Given this list of marker genes ZNF385C, CCM2L, G6PC1, ATP1A2, EPPIN, SLC4A1, PPY, TNFRSF9, PLCB2, CIBAR2, NHLH1 (nescient helix-loop-helix 1), HDC, CDH7, CNTNAP2, MYL2, PKLR, OR6B2, SP6, CCDC187, SLC13A2, ABCG5, LCN8, IL17RE, FUT7, KISS1, RD3, TRPM2, NR0B2, KCNIP3, SLC17A7, ADAMTS13, PLCD4, CDHR2, LRCOL1, SEPTIN12, PDZK1IP1, PAX4, SP7, MRGPRG, BTBD17, SLC45A3, MMEL1, CLSTN3, STRA6, ENTPD8, GJA5, C16orf89, WFDC21P, BTNL10P, RNF224, ADAMTSL2, MYO1F, CD207, ABCG8, USP37, FGF23, NTNG2, RGS14, SLC16A8, HAPLN2, PRND, TXNDC8, HTR3B, FNDC8, SOST, GUCY2F, LHX4, PRR15L, BTNL9, KRTAP5-2, CARD14, here is a description of the gene set: Somatic cells can be reprogrammed to a pluripotent state through the ectopic expression of defined transcription factors. Understanding the mechanism and kinetics of this transformation may shed light on the nature of developmental potency and suggest strategies with improved efficiency or safety. Here we report an integrative genomic analysis of reprogramming of mouse fibroblasts and B lymphocytes. Lineage-committed cells show a complex response to the ectopic expression involving induction of genes downstream of individual reprogramming factors. Fully reprogrammed cells show gene expression and epigenetic states that are highly similar to embryonic stem cells. In contrast, stable partially reprogrammed cell lines show reactivation of a distinctive subset of stem-cell-related genes, incomplete repression of lineage-specifying transcription factors, and DNA hypermethylation at pluripotency-related loci. These observations suggest that some cells may become trapped in partially reprogrammed states owing to incomplete repression of transcription factors, and that DNA de-methylation is an inefficient step in the transition to pluripotency. We demonstrate that RNA inhibition of transcription factors can facilitate reprogramming, and that treatment with DNA methyltransferase inhibitors can improve the overall efficiency of the reprogramming process. species: Mus musculus Human Gene Set: MIKKELSEN_MEF_LCP_WITH_H3K27ME3 from publication Mikkelsen TS, Hanna J, Zhang X, Ku M, Wernig M, Schorderet P, Bernstein BE, Jaenisch R, Lander ES, Meissner A (PMID 18509334) Genes with low-CpG-density promoters (LCP) bearing the tri-methylation mark at H3K27 (H3K27me3) in MEF cells (embryonic fibroblasts).